The following is a description of a gene set: Microarray analysis was performed to determine the transcriptional profiles of NKT, CD1d-aGC+ Va24-, and CD4 T cells. Genes up-regulated in naïve T cells: CD4 versus NK. from publication Constantinides MG, Picard D, Savage AK, Bendelac A (PMID 21632718) studied in species Homo sapiens Human Gene Set: GSE28726_NAIVE_CD4_TCELL_VS_NAIVE_NKTCELL_UP, and this is the list of marker genes: SP3, PSMD7, MKLN1, PGAP1, DNAJC7, PDCD1, PGAM1, SRGN, RCE1, NELFE, RAD1, ADAM19, CDS2, TOR1B, IER3, ATF3, GSDME, CSTB, EIF4G2, CCT6A, ZYX, FSCN1, GAPDH, TAF1B, RHOG, GABPB1, KIF3A, PRKD3, EMG1, GBP1 (guanylate binding protein 1), CCL20, RAB22A, RGS10, NOL7, SLC25A16, PER2, MATK, RP2, RRAS2 (RAS related 2), GNG5, RANBP2, SS18L1, HIVEP2, PWP2, RARA, IL18R1, AHR, UAP1, GFI1, NOLC1, SLC7A5, PSMB5, PNO1, SPAG1, NFE2L2, CA2, IDS, C5orf22, GLS, DPY19L2P2, ISG20L2, EGR3, AP1S2, CD58, NSMAF, CD9, EIF4E, POGZ, SNRPG, BCL2A1, NUBP1, ACSL3, MAP2K3, PLP2, TUBG1, RNF14 (ring finger protein 14), LYSET, IRF4, CCL4, NFKB1, AMD1, CCT4, TUBB2A, UTP18, SNAPC5, EGR2, CFLAR, WDR43, SYNCRIP, UBE2D1, FKBP2, PHLPP2, WDR1, ICOS, WBP1L, ZNF195, PEA15, URB2, ZFR2, PPP2CA, HPS5, NOP56, GPX1, TM9SF1, POU2AF1, SNAPC1, WSB2, RRP7A, C6orf120, IMMT, MAPRE2, PAICS, SPRY1, TUBA1A, CALU, COPS8 (COP9 signalosome subunit 8), PRDX1, NDEL1, TRAF1, EVI2B, UTP14C, TMEM243, ATP6V1A, GNAI1, ZFYVE16, ATP2B1, ENO2, CEP170, FEZ2, VIM, CD3D, PEX3, RHEB, FAM98A, HSBP1, S100A11, DUSP5, CHMP2A, EZH2, FEN1, PFAS, UTP3, DYNLL1, LIG4, LAMA3, AHCYL1, TMED9, VASP, JRKL, SEC62, HOMER1, KDM6B, DAAM1, HMGN4, RPN2, CTPS1, YWHAE, EMP1, SERPINB2, CLIC1, WDR47, TP53BP1, RRS1, HOXB2, CAND1, EIF2S1, IPO7, SFXN3, CCDC6, ZPR1 (NCBI Gene Id 95155), NFATC1, C1orf216, HNRNPAB, MACF1, IMPA1, IL1RAP, MAP3K11 (NCBI Gene Id 4296), CD40LG, GABPA, TUBA1B, SERPINE2, CYCS, CD48, TXLNA, INPP5F, FASLG, LCP2, ATXN2, LTBP4, STX1A, UMPS, NECTIN3, NFYA, CD200 (CD200 molecule), SPAG9, ADAM17, SUB1, MUTYH, MTHFD2, CALM2